The following is a description of a gene set: from publication Nakaya HI, Wrammert J, Lee EK, Racioppi L, Marie-Kunze S, Haining WN, Means AR, Kasturi SP, Khan N, Li GM, McCausland M, Kanchan V, Kokko KE, Li S, Elbein R, Mehta AK, Aderem A, Subbarao K, Ahmed R, Pulendran B (PMID 21743478) Genes down-regulated in comparison of peripheral blood mononuclear cells (PBMC) from TIV influenza vaccinee pre-vaccination versus those from day 7 post-vaccination. Systems vaccinology has emerged as an interdisciplinary field that combines systems wide measurements and network and predictive modeling applied to vaccinology. Here we used the systems vaccinology approach to study the molecular mechanisms underlying the innate responses to the trivalent inactivated influenza (TIV) and live attenuated influenza (LAIV) vaccination in humans, and to identify early gene signatures that predict the magnitude of the antibody responses to influenza vaccination. Human Gene Set: GSE29614_CTRL_VS_DAY7_TIV_FLU_VACCINE_PBMC_DN species: Homo sapiens, and this is the list of marker genes: KNL1, PRDX4, ZWINT, GUSBP11, WFS1, RPN2, MANEA, GMPPB, PWWP3B, PARPBP, MKI67, REXO2, UGT2B17, AURKA, SLC39A14, PHTF1, SLC30A5, TNFRSF17, HIBCH, DNAJB11, CDK1, B4GALT3, USO1, CEP55, BUB1, EMC9, MTHFD1, MAN1A1, NUSAP1, IGKV3-20 (NCBI Gene Id 647478), CENPI, MAGEB18, UBE2J1, MCEE, CLINT1, IGHM, STT3A (STT3 oligosaccharyltransferase complex catalytic subunit A), PTTG1, FBH1, SUB1, ATG4A, CEP128, DLGAP5, GINS1, ENSG00000124835, MRPL12, PGM3, ASB3, NUF2, TPM4, GARS1, ADIPOQ (NCBI Gene Id 9370), OSTC, CREB3L2, DCPS, SEL1L3, PPIB, COL4A4, KLHL14, PRPF38A, ITM2C, SCG3, NUDT5, MARS1, LINC02245 (long intergenic non-protein coding RNA 2245), IGKV1D-13, FAM98A, IGLV3-19, MELK, FBXO5, OIP5, CSE1L, POU2AF1, SDC1, MANF, RRM2, SEC11C, MCM2, GULP1, CLPTM1L, SSR3, GLDC (glycine decarboxylase), E2F8, SLC2A5, SPAG5, HSP90B1, SLC44A1, BHLHE41, CENPF, TPX2, HMMR, DENND5B, BUB1B, DSN1, ALG5, CHEK1, TUBG1, MYDGF, TYMS, S100PBP, KIF11, SMC2, UBA5, VOPP1, CRELD2, MZB1, IGKC, COBLL1, MYO1D, TMEM19, ARHGAP42, MYL6B, SDF2L1, RGS13, TRAM2, PDIA5, SEC24A, IGLV1-44, SEC61B, ALG9, FKBP14, INS, KIF15, C11orf24, TPD52, CCNB1, TRIP13, CD38, LMAN1, CDKN3, CCDC167, SLAMF7, HSD17B6, PBK, TXNDC15, GPLD1, CXCR3, TTK, FOXM1, LLCFC1, SPCS1, GPT2, IGLJ3, RTN4IP1, SLC41A2, IGLL3P (NCBI Gene Id 91353), CDC6, ANKRD16, PCLAF, KIF14, PRDM15, GLCCI1, JCHAIN, GNG7, IGKV1-5, XBP1, GPRC5D, ERLEC1, BMAL2, NT5DC2, H4C3, MRPL35, CENPS, DMGDH, EAF2, SRPRB, TOP6BL, CAV1, CFAP263, BFSP2, SHCBP1, EOLA2, GEN1, CHAC2, SPATS2, RASGRP3, MRPS7, PARM1, ZC3HAV1L, ZNG1A, CDC20, SELENOS, SRP54, ZCCHC2, TNFRSF13B, NCAPG, DTL (denticleless E3 ubiquitin protein ligase homolog), GGH, SDHA, CCNB2, EFHC1, KIF4A, IFT25, BLNK